The following is a description of a gene set: A homeostatic process involved in the maintenance of a steady state level of sphingolipids within a cell. Human Gene Set: GOBP_INTRACELLULAR_SPHINGOLIPID_HOMEOSTASIS studied in species Homo sapiens, and this is the list of marker genes: ORMDL3, RTN4, ABCA2, ORMDL1, ORMDL2